Given this list of marker genes ZNF610, TRIM28, H2AC4, HDAC1, ZNF320, UBE2I, H2AC20, H2BC1, H2BC17, H2BC12L, H2AC14, H3C1, H2BC12, ZNF141, H4C1, MBD3, H2AB1, ZNF354A, GATAD2A, SUMO2 (NCBI Gene Id 6613), RBBP4, H2BC3, ZNF224, H2AZ2, ZNF680, RBBP7, H2BC14, CHD3, ZNF28, ZNF534, ZNF519, H3-3A, ZNF30, ZNF93, ZNF669, H2BC9, H2AC7, H2AJ, CBX5, ZNF382, HDAC2, ZNF765, GATAD2B, CHD4, ZNF816, ZNF418, MTA3, ZNF649, MTA1, H3C15, ZNF324, H2AC6, H2BC26, ZNF33A, H2BC4, ZNF273, H2BC5 (H2B clustered histone 5), ZNF454, ZNF257, ZNF264, H2AC18, SETDB1, ZNF778, H2BC11, ZNF317, ATF7IP, ZNF136, ZNF331, H2BC15, H2BC21, MTA2, ZNF547, H2BC13, ZNF708, H2AX, ZNF425, here is a description of the gene set: species: Homo sapiens Reactome Pathway: Regulation of endogenous retroelements by KRAB-ZFP proteins part of: Regulation of endogenous retroelements Krüppel-associated box domain (KRAB) zinc finger proteins (KRAB-ZFPs) contain a transcriptionally repressive N-terminal domain, the KRAB domain, and a C-terminal domain, the ZFP domain, that contains 2-40 zinc fingers and binds specific sequences of DNA. The human genome contains about 352, 378 (de Tribolet-Hardy et al. 2023), or 423 KRAB-ZFP genes, making them the largest family of transcription regulators.<br>About two thirds or more of KRAB-ZFPs bind transposable elements and KRAB-ZFPs appear to coevolve with retroelements such that a KRAB-ZFP binds and transcriptionally silences a specific set of retroelements. The number of KRAB-ZFP genes correlates with the number of retroelements in mammalian genomes and younger retroelements bind fewer KRAB-ZFPs, suggesting an "arms race" in which the evolution of new KRAB-ZFPs is driven by and lags the appearance of new transposable elements.<br>The repressive action of KRAB-ZFPs is mediated by the scaffold protein TRIM28 (also called KAP1), the RBCC domain of which binds the N-terminal KRAB domains of KRAB-ZFPs. TRIM28 autoSUMOylates and recruits effectors, such as the histone H3 lysine-9 trimethyltransferase SETDB1 (also called ESET) and the NuRD repressor complex.<br>The HUSH complex (MPHOSPH8:TASOR:PPHLN1) plays a nonredundant role with TRIM28 in silencing some young LINE1 retroelements, which are only weakly repressed by TRIM28 or HUSH alone.